Given this list of marker genes LYRM7, GRAMD2B, LMNB1-DT, CUL1P1, LMNB1, LINC02147, HSPA8P4, TNFAIP8, KRT8P33, LAMTOR3P2, ENSG00000288008, ISOC1, RN7SL174P, LVRN, HMGB1P22, SNCAIP, PRDM6, MRPS5P3, FABP5P6, RN7SL711P, SNX2, ENSG00000297736, FAM170A, LINC02201, SRFBP1, ALDH7A1, FTMT, ZNF474, LINC02240, LOX, ARL14EPL (ADP ribosylation factor like GTPase 14 effector protein like), RNU7-53P, CHSY3, RNU6-290P, ENSG00000286274, SLC27A6, PHAX, KRT18P16, SLC12A2, CSNK1G3, LINC02208, DDX43P1, ZNF475, COMMD10, RN7SL689P, PRR16 (proline rich 16), RNU7-34P, RPS14P8, RNU6ATAC10P, MINAR2, LINC02215, LINC02214, BOLA3P3, SEPTIN7P10 (NCBI Gene Id 100418707), RNU6-752P, RPL21P58, ENSG00000286615, SLC12A2-DT, PTMAP2, LINCADL (lincRNA adipogenesis and lipogenesis associated), RN7SKP117, LINC02216, HNRNPKP1, HMGN2P27, CEP120, RNU6-718P, SEMA6A-AS1, RNU6-701P, HMGB1P29, MARCHF3, CTXN3, FBN2, RPS17P2, ZNF608, CATSPER2P2, ENSG00000250650, MIR4460, RNU4-69P (NCBI Gene Id 106479590), RNA5SP191, SEMA6A-AS2, ARGFXP1, ZNF474-AS1, MEGF10, SNX24, CCDC192, DTWD2, ADAMTS19-AS1, SELENOTP2, LINC00992, DMXL1, RNU6-373P, RPL35AP15, PRELID3BP8, C5orf63, PRDM6-AS1, HSPE1P10 (heat shock protein family E (Hsp10) member 1 pseudogene 10), LINC02148, SEMA6A, LINC02039, PPIC-AS1, LINC01170, RPSAP37, TUBAP15, MIR1244-2, DMXL1-DT, SPMIP10, RPL7L1P4 (RPL7L1 pseudogene 4), RNU6-644P, ARL2BPP4, ADAMTS19, PPIC, RPL23AP44, MGC32805, MIR5706, HMGB3P17, RNA5SP190, POGLUT2P1, HSD17B4, PRRC1, MIR4633, here is a description of the gene set: studied in species Homo sapiens Human Gene Set: chr5q23